The following is a description of a gene set: Genes predicted to be targets of miRBase v22 microRNA hsa-miR-6529-5p in miRDB v6.0 with MirTarget v4 prediction scores > 80 (high confidence targets). Human Gene Set: MIR6529_5P studied in species Homo sapiens from publication Chen Y, Wang X (PMID 31504780), and this is the list of marker genes: CISD2, THSD7A, SNX16, BTF3 (NCBI Gene Id 689), MXD1, FBXO30, CCSER1, MOSPD1, TAS2R20, BBX, PTPN4, POLD3, RPAP2, FIBIN, PURB, TCF12, NLGN4X, SALL1, WNT11, MAVS, ZBTB18, PCDH9, ANXA5, ANKRD34B, PYROXD1 (NCBI Gene Id 79912), PHB1, MAN2A1, VAPA, KLHDC9, DIP2C, HSPA9, KCNH5, PRKAG1, HDAC9, TMEM248, DNAJC12, AZI2, CDKL5, MEX3C (NCBI Gene Id 51320), NIPSNAP3B, CSTF1, LZTS3, NCOA2, STC1, POP1, INPP4B